The following is a description of a gene set: species: Mus musculus The heterodimeric receptor for granulocyte macrophage colony-stimulating factor. Mouse Gene Set: GOCC_GRANULOCYTE_MACROPHAGE_COLONY_STIMULATING_FACTOR_RECEPTOR_COMPLEX, and this is the list of marker genes: Csf2rb (colony stimulating factor 2 receptor, beta, low-affinity (granulocyte-macrophage)), Csf2rb2, Csf2ra, Csf2, Jak2 (NCBI Gene Id 98155)